The following is a description of a gene set: Genes having at least one occurence of the motif GGCAGCT in their 3' untranslated region. The motif represents putative target (that is, seed match) of human mature miRNA hsa-miR-22 (v7.1 miRBase). studied in species Homo sapiens Human Gene Set: GGCAGCT_MIR22, and this is the list of marker genes: MXD4, POGK, PTEN, GABBR2, PTPN9, DNM3, EDC3, PALD1, MTHFD2, IER5L, KPRP (keratinocyte proline rich protein), STAG2, UBALD1, CLIP2, FGFR2, BOLL, USP37, CDKN1A (cyclin dependent kinase inhibitor 1A), FBXO24, BMP1, PLEKHA6, SATB2, CALM3, RGS2 (NCBI Gene Id 5997), BRSK2, EMX2, AKT3, BOLA2, FAM53C, CCDC47, MXD1, WDFY3, ZFYVE9 (NCBI Gene Id 9372), CSF1R, ZBTB47, DPP4, RIC8B, ZFP91, SLC17A5, CHD7, PDS5A, KALRN, VEZF1, SEPHS1, TP53INP1, TTYH3 (tweety family member 3), ANKRD13A, PPP4R3A, H3-5, TYRO3, RBM3, ARFIP2, KHNYN, CPEB1, BCL9, BIN1, SLC2A1, CBL, KCNK10, AGBL5, CTDSP1, ADAM11, DHX57 (DExH-box helicase 57), HERC4, SLC1A3, HERPUD2, MAP3K12, SLC9A1, WASF1, USP46, NOL4L, NR3C1, HDAC4, MUC1, CARMIL1, ESR1, PIK3CD, GARRE1, FNBP4, HSPG2, TGFBR1, AGO1, CYRIB, KDM3A, TNRC6B, CUL3 (cullin 3), BTG1, FURIN, MAP3K3, KLHL35, SLC9A5, OLA1, CABP7, AQP9, CIAO2A (cytosolic iron-sulfur assembly component 2A), PDZD4, IKZF4, ULK2, SNRK, RAPGEFL1, CCDC88B, EDA, ASB6, CLDND1, TET2, IL17RD, CTIF, ERBB3, ZCCHC14, COPS7B, IL13RA1, DMRTC2, PTPN1, DMRT2, BAGE2, PDIK1L, CENPV, NUDT4, DGKI, STC1, FBXW7, GALT, RIMS4, STAM2, SMAP1 (small ArfGAP 1), BATF3 (basic leucine zipper ATF-like transcription factor 3), CYTH3, PCNX2, PHF20L1, ELF5, ZNF740, MSL2, DFFB, FTL, ARID3B, NAA20, YARS1, TNKS2, IP6K1, CAV3, FBXL19, RYR1, RBM15, MECP2, DNAJC7, WRNIP1, PHF13, MAPK14, IPO7, SLC26A9, IGSF9B, TRIB2, TLK2, EPC1, FOSL1, PURB, BTBD10, ODF1, CALCR, NET1, DPYSL3, HEY2, MUC4, SIRT1, TMEM50B, RFXANK, LAMC1, WDTC1, PRPF38A, FBN2, LIN7C, SNAP91, MAX, CDX2, RAB5B, FOXN3, LPP, ABCB9, MAT2A, LGALS1, BRD4 (NCBI Gene Id 90616), FBRS, NCMAP, EP300, ARRB1, PPP1R15B, AMOT, SRSF10, PDAP1, MVB12B, PHF8, DNAJB5, THADA, TAGLN, ZNF609 (NCBI Gene Id 23060), DHX30, SV2A, FOXP1, DPP10, H3-3B, CHD9, NTRK2, PLAGL2, DPF2, DPY30, SP1, NDEL1, TRUB1, MBP, ADRA1B, RNF38, OGN, MSANTD1, LDLRAD3, NFYA, SLC16A2, HOXA4, LRRC1, BCL9L, EMILIN3, ZBTB39, CLIC4, ARHGEF12 (Rho guanine nucleotide exchange factor 12), MYCL, RCC2, NECAP1, RSBN1, DSCAM, PPARA, STK39, BCORP1